Given this list of marker genes Atf2, Mbnl1, Cnot2, Sall4, Angpt1 (angiopoietin 1), Ncor1, Kmt2d, Stk3, Elf5, Egfr, Cdx4, Alkbh1, Ncoa6, Xrcc2, Usp9x, Traf6, Rad51b, Cebpb, Hey2, Vash2, 9130008F23Rik, Cnot1, Prss29, Krt19, Bmp7, Rbm46, Polb, Gins1, Map2k1, Rspo3, Akap3, Klf2, Nxn, Llgl2, Ascl2, Mapk1, Srf, Fkrp, Suds3, Fgfr2, Igf2, Hand1, Actl6a, Ndufa2, Cts7, Hdac3, Ndel1, Kif3a (kinesin family member 3A), Lef1, Cdk11b (NCBI Gene Id 12537), Ocrl, Notch1, Hormad1, Flvcr1, Tgfbr3, Heg1, mt-Nd4, Prss28, Rtn4, Resp18, Brk1, Csf2, Acvr1, Foxa2, Msh2, Exoc3l2, Mir92-1, Slc34a2 (NCBI Gene Id 52185), Chst11, Gli2, Ncoa3, Stil, Tie1, Slc35e2, Nlrp5, Ubr3, Tgfbr2 (transforming growth factor, beta receptor II), Esx1, G2e3, Ptpn18, Pcdh12, Dll1, Eif2s2, Epn2, Tctn1, Hbegf, Sox8, Plod3, Pelo, Tjp1, Xab2, Twist1 (NCBI Gene Id 22160), Maff, Foxd3, Lrp1b, Nog, Tbx3, Tpm1, Esrrb, Ubtfl1, Mdfi, Sox10, Fosl1, Eno1, Tm4sf1, Ybx3, Nsun2, Nos3, Cnot3, Pemt, Hes1, Emx1 (NCBI Gene Id 13796), Pcgf2, Arnt, Ctnnb1, Oosp1, Epn1, Ednra, Nsrp1, Hes3, Gata6, Myb, Nodal, Gata3, Il10, Ercc2, Hnf1a, Bcl2l11, Npm2, N4bp2l2, Hectd1, Ube2b, Syvn1, Kpna7, Chek1, Lif, Adam10, Tfeb, Cdk2ap1, Nsdhl, Gins4, Tent5c, Zp3, Rundc1, Igf1, Hif1a, Tcf7l2, Wnt3a, Txnrd3, Hsf1, Uspl1, Lig4, Maf, Rpl13, Coq7, St8sia6, Gatad2a, Plcd1, Grin2b, Plac1, Dab2, Taf8 (TATA-box binding protein associated factor 8), Icmt, Msx1, Mosmo, Upf3a, Ccdc62, Mir93, Hcn4, Rtf1, Smarca4, Nr2f2, Flcn, Mgat1, Dbn1, Gli3, Wnt2, Skil, Senp2, Mxi1, Mbd3, Cdkn1c, Atp1b1, Ncor2, Hc, Chd7, Plcd3, Sin3a, Iws1, Sf3b6, Prdm14, Man2a1, Cubn (cubilin), Cts8, Tgfb3, Chtop, Ar, Slc25a34, Ihh, Cul3, Unk, Ptprr, Bysl, H13, Serpina1b, Dusp3, Setd2, Dad1, Mafg, Nle1, Cripto, Notch2, Anks6, Vash1, Mfn2, Myo18b, Med1, Prmt1, Coprs, Amot, Fzd5, Adm, Smad3, Phlda2, Plg, Pitpnb, Xrcc4, Itga4, Nfe2, Capn2, Slc5a7, Camsap3, E2f7, Ttpa, Ttll1, Junb, Prdm1, Psph, Col3a1, Meg3, Setdb1, Tead4, Atf7, Ccdc24, Eomes, Zmiz1, Eif4e2, Sp1, Sox2, Wdr74, Mir18, Sox5, Ncoa1, Srsf1, Gpi1, Fendrr, Hs6st1, Trim28, Ccm2, Ankrd7, Cdh1, Hey1, Nek2, Plpp4 (phospholipid phosphatase 4), Hhex, Zfp14, Runx1, Epas1, Egln1, Ifitm5, Rbpj, Ovol2, Pdgfb, Padi6, Gabpa, Kdm2a, Apba1, Etv2, Suv39h1, Socs3, Pou5f1, Ada (adenosine deaminase), Wdr19, Ctr9, Mybphl, Wnt7b, Tbl1xr1, Nop2, Sp2, Rpgrip1l, Cmtm3, Myo1e, Cited1, Mir25, Taf10, Axin1, St14, Klf4, Agbl4, Rtl1, Pkd1, Pnldc1, Tet1, Mfng, Vcam1, Palb2, Nlrp4f, Bmi1, Prkcsh, 2610005L07Rik, Sec24d, Kat2a, Cdx2, Dnajb6, Fbxw8, Pcdha9, Mrtfb, Insl3, Rrp7a, C2cd3, Zfp36l1, Rbbp8, Chrd, E2f8, Nlrp9c, Rdh10, Med21, Plk4, Ppp4r4, Acvr1c, Gjb3, Sp3, Gata2, Hinfp, Bnip2, Pdzk1, Nrbp1, Polg2, Fgfr1, Ly6e (lymphocyte antigen 6 family member E), Tgfbr1, Furin, Cntnap2, Svet1, Ssr2, Adcy9, Krt8, Dicer1, Pdgfrb, Cpt2 (carnitine palmitoyltransferase 2), Sf3b1, Sco2, Hba-a1, Otud7b, Mir127, Slc39a3, Mir19a, Mib1, Armc5, Pcnt, Cir1, Psmc4, Smad4, Zfp830, Jag2, Gab1, Syde1, Dsc3 (desmocollin 3), Zfand5, Trp53, Kdm8, Sox18, Nbn (NCBI Gene Id 27354), Upb1, Atp11a, Zpr1, Slc8a1, Dcpp1, Slc30a1, Acvrl1, Cmip, Slit2, Mir20a, Rxrb, Dhx35, Endog, Chd8, Ccn1 (cellular communication network factor 1), Hcfc1, Gcm1, Adamts3, Ric8a, Gata4 (GATA binding protein 4), Celf4, Gna13, Fkbp10, Sbds, Slc25a20, Inpp5k, Tab1, Emg1, Foxc1, Rrm2, Grb2, Wdtc1, Apba3, Terf2, Npat, Dll3, Thoc5, Lman1, Grn (granulin), Bcor, Nr5a2, Nasp, Ooep, Ttll4, Etnk2, Zfp335, Zfat, Stk4, Sox15, Rrn3, Inpp5b, Btf3, Hba-a2, Rtcb, 1700067K01Rik, Lats1, Ell, Pramel7, Tmem100, Zfp568, Elf3, Dnaaf2, Cops3, Pth1r, Egfl8, Spic, Apob, Uty, Smg9, Ncapg2, Dmbt1, Nmt1, Mecom, Prrc2b, Smim14, Bmp2, Pkd2, Vegfa, Ccnb1ip1, Zfp420, Matr3, D930028M14Rik, Ggnbp2, Mir106b, Mapk8ip3, Kdm4c, Phf6, Mir17, Tfap2c, Psmc3, Myh6, Mafb, Itgav, Bmpr1a, Kidins220, Bptf, Acvr1b, Sap130, Necab1, Smad2, Speg, Keap1, Rcn1, Snai1, Smo, Supt6, Cdkn1a, Yap1, Foxf1, Sox17 (SRY (sex determining region Y)-box 17), Arhgdig, Sec24c, Bcl2l1, Cited2, Cul4a, Pitx2 (NCBI Gene Id 338526), Zfp42, Brd4, Gdf1, Fbll1 (fibrillarin-like 1), Specc1, Hand2, Asf1b, Apba2, Gna12, Xist, Sox6, Zbed6, Klf1, Stmn3, Nrk, Crxos, Nlrp9b, Thoc2, Hs3st6, Ccnb2, Rnaseh2b (NCBI Gene Id 68517), Gse1, Spint2, Kifbp, Sh3pxd2a, Wnt9b, Mtss1, Rxra, Rmrp, Lpar6, Kdm4dl (lysine (K)-specific demethylase 4D-like), Hopx, Ube2a, Rpl7l1, Add1, Tanc2, Ccnk, Zbtb18, Cops2 (COP9 signalosome subunit 2), Bap1, B9d1, Synb, Ints1, Spint1, Hnf1b, Flvcr2 (NCBI Gene Id 217721), Gata1, Ptch1, Lats2, Pbrm1, Erf, Ccnb1, Gjb5, Rpa1, Tex19.1, Itgb1, Arnt2, Vps54, Hsd17b2, Bmp5, Ankrd11, Ttn, Gdf3, Birc6 (NCBI Gene Id 353075), Ythdc1, Grhl2, Ybx1, Myh9, Rbbp6, Cr1l, Nlrp9a, Epb41l5, Ppp1cc, Nckap1, Mir19b-1, Tmem231, Brca2, Pdgfra, Cebpa, Tshz3, Kdm6a, Smpd4, Diaph3, Tmed2, Slc39a1, C6, 4933434E20Rik, Plcg1, Gja1, Syna, Zfpm2, Syf2, Myh10, Akt1, Cert1, Edn1, Ctcf, Smarcb1, here is a description of the gene set: The process whose specific outcome is the progression of the embryo in the uterus over time, from formation of the zygote in the oviduct, to birth. An example of this process is found in Mus musculus. studied in species Mus musculus Mouse Gene Set: GOBP_IN_UTERO_EMBRYONIC_DEVELOPMENT